The following is a description of a gene set: Mouse Gene Set: GOBP_COBALAMIN_TRANSPORT species: Mus musculus The directed movement of cobalamin (vitamin B12), a water-soluble vitamin characterized by possession of a corrin nucleus containing a cobalt atom, into, out of or within a cell, or between cells, by means of some agent such as a transporter or pore., and this is the list of marker genes: Abcc1, Cubn, Amn1, Tcn2, Abcd4, Cd320, Amn, Cblif